Given this list of marker genes SCN5A, ADRA1A, NPS, GBA1, TRPM4, TAC1, SLC9A1, TACR1, TNF, here is a description of the gene set: Any process that activates or increases the frequency, rate or extent of action potential creation, propagation or termination. This typically occurs via modulation of the activity or expression of voltage-gated ion channels. Human Gene Set: GOBP_POSITIVE_REGULATION_OF_ACTION_POTENTIAL species: Homo sapiens